Given this list of marker genes Fgfr1, Hgf, Fgf7, Fgf10, Met, here is a description of the gene set: Any process that modulates the rate, frequency, or extent of branching involved in salivary gland morphogenesis as a result of signals being generated by the mesenchyme and received and interpreted by the salivary gland epithelium. species: Mus musculus Mouse Gene Set: GOBP_REGULATION_OF_BRANCHING_INVOLVED_IN_SALIVARY_GLAND_MORPHOGENESIS_BY_MESENCHYMAL_EPITHELIAL_SIGNALING